The following is a description of a gene set: Human Gene Set: MIR340_3P from publication Chen Y, Wang X (PMID 31504780) species: Homo sapiens Genes predicted to be targets of miRBase v22 microRNA hsa-miR-340-3p in miRDB v6.0 with MirTarget v4 prediction scores > 80 (high confidence targets)., and this is the list of marker genes: TAPBP, TULP4, INMT, HUS1, ZC3H6 (zinc finger CCCH-type containing 6), TMEM170A, SPACA9, SPCS3, VPS33A, LRRC51, S1PR2, ZFP64, TPM3, SEC61A2, SLC16A4, ZNF7, ZNF835, APOBEC3F (apolipoprotein B mRNA editing enzyme catalytic subunit 3F), C15orf40, ACTR10, UPK3BL1, EIF4E, ATAD5, ZNF805, JPH3, MBOAT1, QPCTL, CYB5R3, EPHA3, SHOX, ZBTB8OS, TMEM41B, ZNF816-ZNF321P, LIX1L, DCAF16, CTSV, ZNF814, INPP5B (NCBI Gene Id 3633), SLU7, SLC36A2, TLCD2, R3HDM2, ZNF850, SINHCAF, NOP14, RWDD2A, TMED4, TSPYL1, ZSCAN2, ATXN3